The following is a description of a gene set: Anasarca Human Gene Set: HP_ANASARCA An extreme form of generalized edema with widespread and massive edema due to effusion of fluid into the extracellular space. species: Homo sapiens, and this is the list of marker genes: PMM2, NPHS1, PLVAP, DPAGT1, UBR1, POLG, DEF6, PRKAG2, FARSB, SCARB2